Given this list of marker genes Siglece, Bod1l, Rad54b, Gnrhr, Arhgap42, Cacna1h, Prkab2, Zc3h12d, Camk2d, Pnpla2, Cxcr6, Tpmt, Ano4, Ccdc178, Zc3h12c, G3bp2, Ift57, Prox1, Abca1, Tada2b, Prelid3a, Trim32, Casp6, Fut8, Edrf1, Scamp1, Adam22, Katnal1, Hkdc1, Cfap418, Fosl2, Shisa9, Pwwp2a, Sntg1, Oas1g, Rimklb, Crisp3, Nfatc2, Hspa5, Tpr, Prkce, Tgds, Prkag2, Bccip, Vegfb, Trim30d, Prn, Ddx47, Srsf3, Sgk1, Phip, Mat2b, Mroh1, Cideb, Ankfy1, Zfp750, Crisp1, Ctbp2, Lin28a, Tlr2, Zfp9, Sap130, Cartpt, Jdp2, Foxk2, Ticam1, Or51ab3, Plekha8 (NCBI Gene Id 231999), Tlx1, Smim33, Fsbp, Cts3, Hycc2, Rnf150, Larp4, Cdk14, Lef1, Ddx6, Prnd, Heg1, Cers4, Ppfibp1, Thra, Xpo7, Grk3, Swt1, Xrcc4 (X-ray repair complementing defective repair in Chinese hamster cells 4), Tead1, Cep135, Trpm1, Ube2q2, Scn2a, Usp24, Phka2, here is a description of the gene set: Mouse Gene Set: MIR_1970 Genes predicted to be targets of miRBase v22 microRNA mmu_miR_1970 in miRDB v6.0 with MirTarget v4 prediction scores > 80 (high confidence targets). studied in species Mus musculus from publication Chen Y, Wang X (PMID 31504780)